Given this list of marker genes LAMB1, CTR9, LHX1, BRD3, EOMES, DKK1, SOX17, ITGA7, DUSP4, MYH9, ENSG00000285205, ITGA4, GATA6, COL11A1 (collagen type XI alpha 1 chain), SOX7, MMP9, FN1, ITGB5, MMP14, TBX20 (NCBI Gene Id 57057), PAF1, ITGA5, LEO1, COL7A1, RTF1, HSBP1, COL4A2, INHBA, MMP2, MESP1, COL5A2, HMGA2, ITGB2, GRB2, ITGAV, NR0B1, MACROH2A1, MAP2K1, SMAD2, COL8A1, DUSP1, COL5A1, CDC73, LAMA3, DUSP2, LAMB3, MMP15, NOG (noggin), SETD2, COL6A1, DUSP5, VTN, POU5F1, CTNNB1, HNF1B, NANOG, MIXL1, NODAL, SOX2, COL12A1, MMP8, here is a description of the gene set: The formation of the endoderm during gastrulation. studied in species Homo sapiens Human Gene Set: GOBP_ENDODERM_FORMATION